Given this list of marker genes Cdc42, Gli1, Faf1, Cacybp, Cdk1, Cdc7, Fgfr1, Stn1, Cst3 (cystatin C), Gli2, Ssbp1, Map2k4, Kat7, Baz1a, Npm1, E2f8, Pcna (NCBI Gene Id 18538), Jun (NCBI Gene Id 16476), E2f7, Brpf3, Atf1, Dbf4, Hras, Ctc1, Atad5, Dhx9, Cdk2, Mas1, Ager, Dna2, Mapk8, Smarca5, Atrx, Npm2, Endog, Lpin1, Egfr, Tnfaip1, Ucn, Mtnap1, Ino80, Met, Ereg, Il6, Wiz, Kctd13, Ciz1, Pdgfb, Cdt1, Rac1, here is a description of the gene set: species: Mus musculus Any process that activates or increases the frequency, rate or extent of DNA replication. Mouse Gene Set: GOBP_POSITIVE_REGULATION_OF_DNA_REPLICATION